Given this list of marker genes Spred1, Ifi211, Steap3, Chd5, Atr (ataxia telangiectasia and Rad3 related), Ppp1r15a, Eef1e1, Rpl37rt, Rpl37, Ing4, Rpl11, Spred2, Sh3glb1, Rpl26, Rps7, Pla2r1, Zfp385a, Ubb, Ifi205, Rps15, Trp73, Hexim1, Pmaip1, Ankrd1, Bmyc, Rpl23, Ddx5, Hic1, Ifi204, Pml, Knl1, Msx1, Rps20 (NCBI Gene Id 67427), Cdkn2a, Atm, Znhit1, Cdk5rap3, Myc, here is a description of the gene set: studied in species Mus musculus Any process that activates or increases the frequency, rate or extent of signal transduction by p53 class mediator. Mouse Gene Set: GOBP_POSITIVE_REGULATION_OF_SIGNAL_TRANSDUCTION_BY_P53_CLASS_MEDIATOR